The following is a description of a gene set: Human Gene Set: HP_LOW_MOLECULAR_WEIGHT_PROTEINURIA studied in species Homo sapiens Low-molecular-weight proteinuria Excretion in urine of proteins of a size smaller than albumin (molecular weight 69 kD)., and this is the list of marker genes: CLCN5, NDUFAF6, OCRL, GATM, SLC34A1 (solute carrier family 34 member 1), EHHADH, CTNS